Given this list of marker genes Id3, Flt1, Smad4, Id2, Ccne1 (NCBI Gene Id 12447), Msc, Smad3, Acvrl1, Smad1, Myog, Rela, Kdr, Myf6, Elk1, Bmp2, Cdk2, Ngf, Id4, Pax8, Egf, Pax5, Tcf12, Tert (NCBI Gene Id 21752), Myf5, Psmd4, Pax2, Rbl2, Irs1, Igf1, Atf3 (activating transcription factor 3), Myod1, Cd40lg, Bmpr2, Hes1, Rb1, Vegfa, Tcf3, Srebf1, Nfkb1, Rbl1, Igf1r, Tcf7l2, Lck, Ctnnb1, Ccna2, Elk4, Elk3, Smad5, Id1, Tgif1, here is a description of the gene set: ID signaling pathway studied in species Mus musculus Mouse Gene Set: WP_ID_SIGNALING_PATHWAY